Given this list of marker genes PLA2G15, ATF7IP, CERS5, LMBRD2, REEP3, ARHGAP45, VAV3, PIP4K2A, EDEM1, INPP4A, ENGASE, RHOD, RXRA, CERK, PHKA1, SETX, EXOC4, SOAT1, FASN, SLC44A2, ERP29 (NCBI Gene Id 10961), PGAP6, SP3, SSBP3, TBC1D24, DAGLB, RCBTB1, SLC38A9, TBC1D8, FMNL1, SFXN5, KLHL6, USP8, SUMF1, FNBP1, ST6GAL1, PAG1, MEF2C, APPL2, NCOA1, RGS2, PI4KA, SIAE, OTULINL, IFT140, FAM76B, IQSEC1, TANC1 (tetratricopeptide repeat, ankyrin repeat and coiled-coil containing 1), CNPY4, ATMIN, WDR26, PANK1, PTP4A2, ATRX, SETD2, PYGB, HDAC5, NDST2, SEC16A, ETAA1, ARHGEF1, TMEM154, SCAMP5, FCHO2, TERF2, HPS4, NFATC2, ATP10D, NFXL1, NBEAL2, NDST1, ITSN1, TCTN3, RGMB, SLC25A39, OSBPL11, MBNL1, MKNK2, DOP1B, GNAI2, ZFHX3, SDCCAG8 (NCBI Gene Id 10806), PREX1, IGFBP4, SEC14L1, TMEM106A, PLEKHF1, GAPVD1, DIS3L2, PPP3CA, RFC1, UBR7, TM9SF1 (transmembrane 9 superfamily member 1), AP2A2, AKT1, MAP3K12, FAM110B, CELF2, SIPA1, TCN2, PRPS2, FAM168B, PJA2, TRAPPC12, NCOA3, TPCN1, S100PBP, SNX33, TMEM64, CUL4A, FBXL4, NUTF2, XPR1, SESN1, NISCH, TBC1D22A, MPP1, CLTC (NCBI Gene Id 9511), ARL15, TGFBRAP1, SNX29, AP3D1, APOBEC1, WDR91, UPRT, TNKS2, VPS13B, RANBP9, ASB13 (NCBI Gene Id 79754), CTDSP1, GNS, RNF144B, ZFAND4, RNF157, EPN1, ZBTB14, EIF2AK3, KIF16B, GGCX, MYO1F, PHACTR2, UVRAG, GBA2, SLC43A2 (NCBI Gene Id 124935), TBL1XR1, CXCR4, GABPB2, SIRPA, PBX2, SLC7A4, ZDHHC14, TBC1D25, UBE4B (NCBI Gene Id 10277), ANKRD54, CEP295NL, ADAMTS10, C2CD2, ADIPOR1, INTS6L, LMO2, PSME4, PHF20, RTN3, SCAMP2, FOXN3, AP1S2, DOCK2, DEPDC5, MSH3 (NCBI Gene Id 4437), TTLL4, MAN1B1, GLE1, TTLL5, ATP6V1A, TFDP2, PPIP5K1, SNRK, SNX5, MAP3K1, CPEB1, C3AR1, here is a description of the gene set: We used microarrays to compare interferon-alpha (IFNa)- and interferon-gamma (IFNg)-stimulated genes under an equivalent biological input. The goal was to compare IFNa- and IFNg-stimulated genes, as well as to identify common and distinct sets of type I and II ISGs. from publication Liu SY, Sanchez DJ, Aliyari R, Lu S, Cheng G (PMID 22371602) Human Gene Set: GSE35825_UNTREATED_VS_IFNG_STIM_MACROPHAGE_DN studied in species Homo sapiens Genes down-regulated in bone marrow-derived macrophages: untreated versus stimulated by IFNG.